The following is a description of a gene set: species: Homo sapiens Genes important for mitotic spindle assembly. Human Gene Set: HALLMARK_MITOTIC_SPINDLE from publication Liberzon A, Birger C, Thorvaldsdóttir H, Ghandi M, Mesirov JP, Tamayo P (PMID 26771021), and this is the list of marker genes: PCGF5, HDAC6, DOCK2, KIF3B, KIF23, TSC1, GEMIN4, YWHAE, NEDD9, RABGAP1 (RAB GTPase activating protein 1), MAPRE1, CTTN, KIFAP3 (kinesin associated protein 3), CDC42 (cell division cycle 42), RANBP9, EPB41, MARK4, CENPE, TLK1, NUSAP1, ACTN4, PKD2, EPB41L2, PPP4R2, SPTAN1, CDC42BPA, NUMA1, KIF15, TOP2A, ALS2, MYO1E, STK38L, ITSN1, GSN, ARHGEF3, ARHGAP10, CCNB2, NF1, ARHGAP5, NCK1, ARAP3, SORBS2, SEPTIN9, PDLIM5, SASS6, TUBGCP6, CDK5RAP2, CKAP5, TUBD1, CSNK1D, DST, ARHGEF11, SUN2, RAPGEF6, RASAL2, SMC4, TAOK2, SMC1A, KIF2C, PLK1, TUBGCP3, CAPZB, ALMS1, CNTROB, KLC1, FARP1, UXT, AKAP13, MARCKS, ESPL1, BIN1, ANLN, HOOK3, APC, CEP192, CYTH2, PCNT, MYH10, ARHGEF7, ARHGEF2, CNTRL, NIN, DYNLL2, WASL, CDK1, ROCK1, MAP1S, ARHGEF12, CENPJ, NEK2, SOS1, PRC1, DOCK4, LRPPRC, FBXO5, CLIP1, LATS1, RASA2, ARF6, MID1, TTK (NCBI Gene Id 7272), CENPF, DYNC1H1, KIF11, KATNA1 (katanin catalytic subunit A1), SMC3, ARFGEF1, BUB1, OPHN1, WASF1, ECT2, MID1IP1, FSCN1, KIF4A, RHOF, ARHGAP4, NCK2, SAC3D1, DLGAP5, KATNB1, KPTN, RICTOR, RFC1, PAFAH1B1, DLG1, RALBP1, KIF1B, NOTCH2, ABI1, SSH2, ARHGDIA, SPTBN1, RACGAP1, KIF3C, RAPGEF5, CDC42EP2, CCDC88A, CEP250, CLASP1, CEP72, RASA1, KIF20B, FLNA, BIRC5, BCR, TRIO, MYO9B, SYNPO, FGD6, TBCD, STAU1, PXN, PALLD, CDC42EP1, ARHGAP27, CD2AP, FLNB, SHROOM1, TUBA4A, LLGL1, CEP131, KIF22, PLEKHG2, PCM1, ARHGAP29, LMNB1, AURKA, RAB3GAP1 (NCBI Gene Id 338380), VCL, ARFIP2, TUBGCP5, BCL2L11, BRCA2, PREX1, RHOT2, CEP57, ABL1, TPX2, FGD4, BCAR1, INCENP, SHROOM2, TIAM1, EZR, MAP3K11, KIF5B, NET1, KNTC1, WASF2, TUBGCP2, MYH9, CDC42EP4, PIF1, ATG4B, ARL8A, NDC80, CDC27, ABR, CLIP2